Given this list of marker genes FGF6, FGF3, FGF4, SHC1, PTPN11, FGF23, FGF5, KL, FGF9, PIK3C3, PIK3R2, HRAS, AKT2, FRS2, FGF19, FGF7, IRS1, FGF1, NRAS, GRB2, FGFR2, PDE3B, PIK3CB, TLR9, FGF22, KRAS, GAB2, PIK3R4, KLB, TRIB3, GAB1, IGF2, FGF17, THEM4, IRS4, FGFR4, FLT3LG, IGF1R, IRS2, FGFR1, FGF8, CILP, FLT3, FGFR3, FGF20, FGF18, FGF2, FGF16, PDPK1, IGF1, PIK3R1, FGF10, SOS1, PIK3CA, here is a description of the gene set: Binding of IGF1 (IGF-I) or IGF2 (IGF-II) to the extracellular alpha peptides of the type 1 insulin-like growth factor receptor (IGF1R) triggers the activation of two major signaling pathways: the SOS-RAS-RAF-MAPK (ERK) pathway and the PI3K-PKB (AKT) pathway (recently reviewed in Pavelic et al. 2007, Chitnis et al. 2008, Maki et al. 2010, Parella et al. 2010, Annunziata et al. 2011, Siddle et al. 2012, Holzenberger 2012). part of: Signaling by Receptor Tyrosine Kinases Reactome Pathway: Signaling by Type 1 Insulin-like Growth Factor 1 Receptor (IGF1R) species: Homo sapiens